The following is a description of a gene set: Human Gene Set: GSE32164_RESTING_DIFFERENTIATED_VS_CMYC_INHIBITED_MACROPHAGE_UP from publication Pello OM, De Pizzol M, Mirolo M, Soucek L, Zammataro L, Amabile A, Doni A, Nebuloni M, Swigart LB, Evan GI, Mantovani A, Locati M (PMID 22067385) Genes up-regulated in macrophages: resting differentiated versus MYC inhibited. In response to microenvironmental signals macrophages undergo different activation, indicated as classic/M1 and alternative/M2 polarization. C-Myc transcription factor could be an essential player in M2 polarization. Functional relevance of c-Myc in M2 macrophage biology is investigated by evaluating the effect of 100-58F4, on the transcriptional profile induced on human macrophages by IL-4. studied in species Homo sapiens, and this is the list of marker genes: TRIM59, SLC4A1, BDKRB1, KIAA0930, GNB4, EEA1, ID3, SLC27A4, IL9, CBFA2T3, CMTM4 (NCBI Gene Id 146223), URM1, BIRC3, LRRC8A, INHA (inhibin subunit alpha), KRT84, CD19, LAMP2, C1R, EBF1, CTSH, APEX1, PLTP, ACP1, TPD52, GPR143, CRYBB2, CRAT, SPI1, CDKN2D, TFAP2A, SNX9, PHTF2, ADAM9, IRF8, CPNE6 (copine 6), WEE1, TLCD4 (NCBI Gene Id 148534), SMIM14, CD22, TCF4, ODF1, CXXC5, KLF7, OXT, MARCHF7, HIP1R, ALCAM, RASGRP2, RIMOC1, MYO1E, MYADM, PRCC, MTM1, LIMD1, NKX6-2, CD37, FGFR4, TPST1, MBD4, ADRB2 (adrenoceptor beta 2), POLE3 (NCBI Gene Id 54107), BCL6, TACR2, DDHD1, MTCP1, TXNDC16, JARID2, IL4I1, CEP89, PML, OC90, C1QL1, ARHGAP21, POLD1, POU2AF1, SLC30A5, PSPC1, HOXC6, BFSP1, WNT10B, PKIB, GSN, TBC1D23, NR5A1, IRF5, MAN1A1, MEF2C, CAPN5, IGHM, MCOLN2, SYPL1, ZNF532, TLE1 (NCBI Gene Id 7088), MAP3K1, TMT1A, GRIN2D, TEC, SLC30A4, PXK, FOXP1, CIITA, VCL, SLC16A7 (solute carrier family 16 member 7), EPHA7, FCGRT, TFAM, P2RX4, SMPD2, RALB, TNFAIP2, ZNHIT3, LAMB3, STAR, SERP1, PRKCD, PDE6A, TUBB6, IQGAP1, CNN3, MYO5A, POLR2I, MARCKS, TYR, WIPI2, PRRC1, CTSC, RALGPS2, GAD1, ATP7B, LAT2, ANKRD1, DNAJB4, HCRT, SLC32A1, OAT, S1PR1, ALDH2, ZC3H12C, C9orf85, CD40, CASP9, SELL, RRAGA, RASD1, CD81, SYK, ADH7, MGAT1, TOMM70, HLA-DOB, LYN, NAP1L1, HSD17B1, IRF4 (NCBI Gene Id 4592), HLA-DMB, CPSF2 (cleavage and polyadenylation specific factor 2), COL1A2, CLIC4 (chloride intracellular channel 4), HS3ST1, CENPA, LDB2, GNA12, CDH6 (NCBI Gene Id 1004), CLCN5 (chloride voltage-gated channel 5), GPX1, RPL35A, ITSN1, CTSS, APOA1, NSD1 (nuclear receptor binding SET domain protein 1), MINDY1, ITGA4 (integrin subunit alpha 4), PTPN6, CA2, RYR1, ERO1B, SERPING1, MYO7A, SPIB (NCBI Gene Id 6689), GGA2, CAPN6, TACSTD2, GCK, PKIG, SQLE, RAPSN, DNAJC9, ZDHHC14, MPG, CD38, EBI3, CENPB, CDT1, CCR6, BTK, EPB41L2, FCGR2B, GABRA3, GADD45A